The following is a description of a gene set: species: Homo sapiens Human Gene Set: GOBP_REGULATION_OF_CHROMOSOME_ORGANIZATION Any process that modulates the frequency, rate or extent of a process involved in the formation, arrangement of constituent parts, or disassembly of a chromosome., and this is the list of marker genes: CDC23, ANAPC7, MRE11, SENP6, ANAPC4, PNKP, TERF2, ANAPC1 (NCBI Gene Id 64682), PLK1, SMG5, DYNC1LI1, LIG4, WAPL, RNF4, CCT2, YLPM1, XRCC5, SLF1, MYC (MYC proto-oncogene, bHLH transcription factor), CDC6, RIOK2, NCAPH2, CENPE, RAD50, SMARCC2, RMI2, PPP1R10, SPDL1, NSMCE2, USP44, HASPIN, NAT10, AXIN2, SPC25, TRIP13, BUB1B, AURKB (NCBI Gene Id 9212), ACTL6B, USP7, TEX14, INO80, BCL7C (NCBI Gene Id 9274), FSHR, PINX1 (NCBI Gene Id 91819), PHF10, ZW10, TNKS2, CCT3, BRD7 (NCBI Gene Id 29117), ACD, TTK, ANAPC15, EXOSC10, BUB1, KLHL22, CCNB1, ANAPC5, NAF1, MAPK15, TP53, INO80D, KAT2B, GNL3L, TINF2, XRCC3, UCHL5, SMC4, NCAPD3, DDX11, TERF1, TNKS, SMARCC1 (SWI/SNF related, matrix associated, actin dependent regulator of chromatin subfamily c member 1), NEK6, YY1, CDC16, DPF3, CDC20, HNRNPA2B1, WRAP53, UPF1, KNTC1, NSMCE1, CDK1, NCAPD2, FBXO4, BAZ1B, H3-3A, CTNNB1, PRKCQ, SKA1, APC, HDAC8, MAPT, ZWILCH, ANAPC11, ACTB, ZWINT, TRAPPC12, ANAPC2, DKC1 (dyskerin pseudouridine synthase 1), PSMG2, NFRKB, RUVBL2, PML (PML nuclear body scaffold), NABP2, SMARCB1, MAD2L1BP, TAL1, NCAPH, PARP3, TFPT, CCT6A, TCP1, NEK7 (NCBI Gene Id 148565), HNRNPC, ARID2, LCMT1, BUB3, MAPK3, MCPH1, CCT4, LMNA, RUVBL1 (RuvB like AAA ATPase 1), ERCC1, DLGAP5, POT1, HSP90AA1, ACTL6A, ARID1B, ACTR5, SLX1A, BECN1, ACTR8, SIRT6, CHFR, MAD1L1, CDK5RAP2, SETMAR, MAD2L1, CENPV, TERF2IP, MAPK1, MAD2L2, CENPF, PBRM1, DPF1, SKA3, KNL1, PTGES3, PRAP1, HNRNPA1, NSMCE4A, CDK2, SMC5, BCL7A, SMARCE1, KLF4, SMC2, XRCC1, CCT7, DHX36, SRC, ERCC4, PARN, INO80E, FEN1, MAP2K7, ARID1A, MAPKAPK5, HNRNPU, PARP1, PIF1, MAP3K20, GEN1, PRP4K, TENT4B, SMG6, NSMCE3, NCAPG, SMARCA4, SLX4, HNRNPD, TEN1 (TEN1 subunit of CST complex), ATM, SLF2, CTC1, CCT8, TACC3, ATR, UBE2C, DUSP1, FBXO5, SPC24, HECW2, SLX1B (NCBI Gene Id 79578), MAP3K4, CTCF, KAT5, SHCBP1L, SMC6, INCENP, NEK2, NCAPG2, SMG1, ESPL1, XRN1, CUL3, NAA10, BIRC5, GNL3, DCP2, DPF2 (NCBI Gene Id 5977), MACROH2A1, CDCA8 (NCBI Gene Id 55143), NDC80, SMARCA5 (SWI/SNF related, matrix associated, actin dependent regulator of chromatin, subfamily a, member 5), SFPQ (splicing factor proline and glutamine rich), RAD21, RB1, NUF2, NVL, TPR, ATRX, SIRT1, EID3, SMARCA2, MOS, STN1, SMARCD2, H3-3B, SMARCD1, BCL7B, CDC27 (NCBI Gene Id 996), INO80B (NCBI Gene Id 83444), INO80C, ZNF207, IK, MCRS1, RTEL1, NUMA1, PKIB, SMARCD3, NBN, CCT5